The following is a description of a gene set: Human Gene Set: GOMF_DNA_BINDING_TRANSCRIPTION_ACTIVATOR_ACTIVITY A DNA-binding transcription factor activity that activates or increases transcription of specific gene sets. species: Homo sapiens, and this is the list of marker genes: TCF4, ELF1, NKRF, SP100, HOXA13, MEIS3, PITX3, NFAT5, NR4A2, TFAP2B, E2F2, PBX1, FOXN1, FOXH1, HOXB2, HOXB5, HOXB3, CEBPA, GCM1, FEZF2, PLAGL2, GRHL1, ZNF341, NR1H3, RFX6, ESRRA, NR6A1, MYBL1, ATF4, ZNF395 (NCBI Gene Id 55893), TBX19, MAFB, ARNT2, GCM2, POU4F2, SCX, TEAD1, POU4F3, PRRX1, ZSCAN21, NKX2-8, HOXA10, RFX4, BNC1, BCL11B, RFX5, NFIB, TFDP1, ZIC1, ETV6, ATF6B, FOXA2, HNF4G, ZNF24, TCF21, MZF1, TFAP4, NFYC, ALX4, MAFG, TLX1, PAX5, PHOX2B, FOXI1, ONECUT1, SOX30, EGR2, NKX6-1 (NK6 homeobox 1), RAX2, OTX1 (NCBI Gene Id 93105), AR, ELK4, ALX1, STAT6, MYBL2, FOXP3, EGR1, PRDM4, CARF, HOXD10, SATB2, CASZ1, SOX2, GLIS1, FLI1, SOX15, NKX2-2, E2F1, CDX1, SOX11, CEBPD, TLX2 (T cell leukemia homeobox 2), TCF12, ZNF784, ATOH1, PAX9, MEIS2, EGR3, HINFP, MEF2B, MSGN1, SIX4, TFDP2, ETV4, DMRT1, SOX10, YY2, PGR, GATA2, MEF2A, TFEC, ZNF597, GATA4, HLF (HLF transcription factor, PAR bZIP family member), MAFA, LMX1A, NOTCH2, IRF1, CREB3L4, NFKB1, SOX21, IRX6, NFATC2, CREB3, PHOX2A, JUN (Jun proto-oncogene, AP-1 transcription factor subunit), SOX17, ELF3, GBX2, NKX6-3, ZNF131 (NCBI Gene Id 7690), MEOX1, FOXD1, DBP, YY1, FOXC1, SPI1, POU2F3, ONECUT2, MYC, ATF5, TFAP2D, PLAG1, ZNF175, BARX2, HNF1A, HEYL, SALL2, FOXA1, MYF5 (NCBI Gene Id 4617), SOX1, NRL, MEOX2, ESRRG, ETV2, ZNF76, HAND1, RORB, TEAD4, POU1F1, NR2E1, BHLHA15, SOX4, LHX2, NKX2-6, ZNF780B, CEBPB, BATF, TBX21, HOXC4, FOS, NEUROD1, THAP11, MYF6, SOX12, NR3C1, JUND, RUNX2, RFXANK, GATA3, TFAP2C, FOXR1, SIX3, SP1, PROP1, ETS1, DMRT2, BACH1, CEBPG, FOSL2, ZNF71, GLIS2, CREB3L3, ATF2, SPIB, DUX4, SOX18, NR4A1, FOXF1, ZNF750, KLF15, ATF6, PTF1A, MYB, MYT1L, SP7, ZFAT, EHF, SIX5, RAX, ASCL2, PBX3, MLXIP, CRX, IRF2, RBPJL, ZIC3, IRF3, VEZF1, TBX3, OSR2, FEV, POU3F2, ESR1, MECOM, ZEB2, LEF1, WT1, ISL1, BORCS8-MEF2B, TCF3 (NCBI Gene Id 6929), FOXO4, ZFY, NFIA, ZNF292, ERG (ETS transcription factor ERG), PAX6, CLOCK, SIX1, HOXD3, EPAS1, SMAD1, KLF6, HOXC13, RBPJ, RXRB (retinoid X receptor beta), BARHL1, MYOD1, PRDM2, NEUROD6, NR1I2, ARX, TCF15, KLF5, LHX3, IRX3, TFE3, TFEB, HSF5, RLF, HOXA9, LITAF, REL, TFAP2E, HAND2, MAFF, NHLH2, SOX14, IRF6, ATF3, GRHL3, SRY, ZBED4, FOXJ2, CREB1, POU4F1, HDAC4, IKZF3, PDX1, DLX3, CREB3L2, ZNF485, MIXL1, ETV5, HIF1A, RREB1, CREBRF, KLF4, NFATC3, SMAD2, MEIS3P1, GMEB1, SRF, FOXO3, MITF, UBP1, ZNF345, SOX7, FOXJ1, CSRNP1, TP73, CDC5L, ZBTB16, HHEX, ATF1, KLF7, FOXC2, ELK1, ZNF212, HOXD4, CEBPE, TFAP2A, DDIT3, PBX2, MYCN, CSRNP3, MAF, NR1H4, USF2, HNF4A, NR2C2, HOXB1, OTX2, GRHL2, BARHL2, EBF4, SPIC, ZBED1, STAT5A, LHX4, PROX1, GABPA, IRF4, GLIS3, EGR4, ESRRB, CDX4, NFIC, MTF1, ZFX, TBX5, PRDM15, NR5A2, PRDM16, HOXC10, HOXA5, DLX2, SMAD4, NPAS4, GSX1, RUNX1, E2F4, USF3, SMAD3, NR1I3, STAT5B, SOX3, CSRNP2, CREB3L1, GFI1B, NFE2L1, NEUROD2, EN2, ZNF329, SIX2, EBF2, NFATC1, GATA1, E2F3, MSX1, PPARA, NOTCH1, NRF1, TP63, MEF2C, PPARG, JUNB, ATMIN, FOXO1, ZBTB7B, RFX2 (NCBI Gene Id 5990), ZNF580, NR1H2, HOXA1, FOXD2, FOXK2, IRF5, FIGLA, HOXA7, TP53, STAT3, RELA, FOXF2, FOSB, PLAGL1, HSF1 (NCBI Gene Id 642255), MEIS1, TBX20, CTCFL, ZNF300 (NCBI Gene Id 91975), HSF2, HOXB7, E4F1, NHLH1, TFCP2, NEUROG3, ELF5, RFXAP, KLF10, NFE2L2, FOXJ3, ETV1, OVOL2, HOXC11, MLXIPL, ONECUT3, ZNF143, E2F5, USF1, DLX5, GTF2I, MYOG, POU2F1, MESP1, PITX1 (NCBI Gene Id 5307), SHOX, PLSCR1, FOXL2, HDAC5, HOXD8, VENTX, KLF13, NR4A3, IRX4, NFYB, TFCP2L1, NOTCH4, HOXD13, NR2E3, ELF4 (NCBI Gene Id 2000), NKX2-5, GLI1, SOX9, ZNF639, ZBTB17, SREBF1, NFKB2, ELK3